The following is a description of a gene set: Transcriptionally inactive genes which where bound by NF-Y transcription factor. from publication Ceribelli M, Dolfini D, Merico D, Gatta R, Viganò AM, Pavesi G, Mantovani R (PMID 18212061) Human Gene Set: CERIBELLI_GENES_INACTIVE_AND_BOUND_BY_NFY NF-Y is a trimeric transcription factor containing H2A/H2B-like subunits, which specifically binds to the CCAAT box, a common eukaryotic promoter element. To gain insights into NF-Y-dependent transcriptional regulation, we assessed its relationships with positive histone marks by chromatin immunoprecipitation-on-chip and correlative-profiling studies. Unbiased identification of binding sites shows that the majority of genes are bound by NF-Y in the promoter and/or within the coding region. Parallel analysis of H3K9-14ac and H3K4me3 sites indicates that NF-Y loci can be divided in two distinct clusters: (i) a large cohort contains H3K9-14ac and H3K4me3 marks and correlates with expression and (ii) a sizeable group is devoid of these marks and is found on transcriptionally silent genes. Within this class, we find that NF-Y binding is associated with negative histone marks, such as H4K20me3 and H3K27me3. NF-Y removal by a dominant negative NF-YA leads to a decrease in the transcription of expressed genes associated with H3K4me3 and H3K9-14ac, while increasing the levels of many inactive genes. These data indicate that NF-Y is embedded in positive as well as in negative methyl histone marks, serving a dual function in transcriptional regulation, as an activator or as a repressor. species: Homo sapiens, and this is the list of marker genes: S100B, LRRC3, ADORA2A, LINC00158, SYNJ1, CRYBB2, RBM38, PRMT2, RAE1, LINC00315, RIMBP3, MTG2, PLA2G3, P2RX6, RFPL3, MX1, NEFH, LCA5L, ZNF295-AS1, UBE2G2, NRIP1, GAB4, DUXAP10, GAS2L1, CIMIP1, EDN3, CDH26, TTC28-AS1, KCTD17, AATBC, DRICH1, CXADR (NCBI Gene Id 95792), CBR3, IGLL1, PCBP3-AS1, MRAP, FAM230J, GRIK1-AS1, APOL3, POTED, UBASH3A